The following is a description of a gene set: studied in species Homo sapiens Detection of DNA double-strand breaks (DSBs) involves sensor proteins of the MRN complex, composed of MRE11A, RAD50 and NBN (NBS1). Binding of the MRN complex to DNA DSBs activates ATM-dependent DNA damage signaling cascade, by promoting KAT5 (Tip60) mediated acetylation of ATM and subsequent ATM autophosphorylation. Activated ATM triggers and coordinates recruitment of repair proteins to DNA DSBs. part of: DNA Double Strand Break Response Reactome Pathway: Sensing of DNA Double Strand Breaks, and this is the list of marker genes: MRE11, KPNA2, NBN, RAD50, KAT5, ATM